Given this list of marker genes Gal, Tgfb2, Smo, Inhba, Smad4, Pkp3, Foxn1, Hpse, Fst, Tradd, Wnt10b, Dkk4 (NCBI Gene Id 234130), Tnf, Mysm1, Krt17, Msx2, Gsdma3, Wnt5a, Ngfr, Cdh3, Numa1, Fermt1, here is a description of the gene set: Any process that modulates the frequency, rate or extent of hair follicle development. Mouse Gene Set: GOBP_REGULATION_OF_HAIR_FOLLICLE_DEVELOPMENT studied in species Mus musculus